The following is a description of a gene set: Mouse genes annotated to increased adrenal gland tumor incidence (MP:0002031) retrieved from the Mouse Genome Informatics database via MouseMine from publication Motenko H, Neuhauser SB, O'Keefe M, Richardson JE (PMID 26092688) studied in species Mus musculus Mouse Gene Set: MP_INCREASED_ADRENAL_GLAND_TUMOR_INCIDENCE, and this is the list of marker genes: Men1, Inha, Artn, Pten, Nf1